The following is a description of a gene set: species: Homo sapiens Human Gene Set: GOBP_TYPE_2_IMMUNE_RESPONSE An immune response which is associated with resistance to extracellular organisms such as helminths and pathological conditions such as allergy, which is orchestrated by the production of particular cytokines, most notably IL-4, IL-5, IL-10, and IL-13, by any of a variety of cell types including T-helper 2 cells, eosinophils, basophils, mast cells, and nuocytes, resulting in enhanced production of certain antibody isotypes and other effects., and this is the list of marker genes: IL10, CD86, BATF, ECM1, GATA3, BCL6B, IL6, NOD2, STAT6, IFNA2, NDFIP1, BCL6, IL4R, STARD7, TRAF3IP2, IL4, BCL3, IFNB1, IFNL1, ARG1, IGHE, CD81, ANXA1, IDO1, CD74, MEN1, TBX21, ASCL2 (NCBI Gene Id 430), XCL1, MYB, KMT2A, FCER1A, CCR2, IL33, IL27RA, NLRP3, RSAD2, RARA, TNFSF4, IL18, ARG2, HLX, PRKCZ, DENND1B, SOCS5